The following is a description of a gene set: Any process that decreases the rate, frequency or extent of release of cytochrome c from mitochondria, the process in which cytochrome c is enabled to move from the mitochondrial intermembrane space into the cytosol, which is an early step in apoptosis and leads to caspase activation. Mouse Gene Set: GOBP_NEGATIVE_REGULATION_OF_RELEASE_OF_CYTOCHROME_C_FROM_MITOCHONDRIA species: Mus musculus, and this is the list of marker genes: Prkn, Bcl2l2, Parl, Nol3, Ghitm, Bak1, Ppif, Triap1, Higd1a, Fxn, Gpx1, Bcl2l1, Prelid1 (NCBI Gene Id 66494), Akt1, Arrb2, Mfn2, Hgf, Opa1, Avp, Igf1, Psmd10, Lmna